The following is a description of a gene set: Synostosis involving bones of the feet species: Homo sapiens Human Gene Set: HP_SYNOSTOSIS_INVOLVING_BONES_OF_THE_FEET, and this is the list of marker genes: TPM2, FLNB, ATP7A (NCBI Gene Id 613259), NOG, SMOC1, MAP3K7, FGFR1, TNNI2, MYH3, MKKS, SALL1, CHSY1, BMPR1B, FGFR3, HOXD13, LMBR1, FGFR2, FBLN1, POR, FLNA, TBX4, FGF9, SLC26A2, TNNT3, BHLHA9, GDF6, MAP3K20, GDF5 (growth differentiation factor 5), NALCN, RNU12, GLI3, OFD1